The following is a description of a gene set: Human Gene Set: CHUNG_BLISTER_CYTOTOXICITY_DN species: Homo sapiens Genes down-regulated in blister cells from patients with adverse drug reactions (ADR). from publication Chung WH, Hung SI, Yang JY, Su SC, Huang SP, Wei CY, Chin SW, Chiou CC, Chu SC, Ho HC, Yang CH, Lu CF, Wu JY, Liao YD, Chen YT (PMID 19029983) Stevens-Johnson syndrome (SJS) and toxic epidermal necrolysis (TEN) are life-threatening adverse drug reactions characterized by massive epidermal necrosis, in which the specific danger signals involved remain unclear. Here we show that blister cells from skin lesions of SJS-TEN primarily consist of cytotoxic T lymphocytes (CTLs) and natural killer (NK) cells, and both blister fluids and cells were cytotoxic. Gene expression profiling identified granulysin as the most highly expressed cytotoxic molecule, confirmed by quantitative PCR and immunohistochemistry. Granulysin concentrations in the blister fluids were two to four orders of magnitude higher than perforin, granzyme B or soluble Fas ligand concentrations, and depleting granulysin reduced the cytotoxicity. Granulysin in the blister fluids was a 15-kDa secretory form, and injection of it into mouse skin resulted in features mimicking SJS-TEN. Our findings demonstrate that secretory granulysin is a key molecule responsible for the disseminated keratinocyte death in SJS-TEN and highlight a mechanism for CTL- or NK cell--mediated cytotoxicity that does not require direct cellular contact., and this is the list of marker genes: PLCG2, C12orf76, IGKC, MAX, FKBP1A, PPM1A, VCL, CFP, MTPN, MAML3, RGS18, PDLIM1, IGLC2, ITGB2-AS1, RAP1GAP2, GRB10, JPX, KIAA0513 (NCBI Gene Id 9764), SLC40A1, ADD3 (adducin 3), CSTA, HACD4, STXBP5, FOXP1, PRKCB, GAS7, GCA, KAT2B, FBXO3, NIN, RBL2, MIR223, H2BC12, PRAM1, SELL, NBEAL2, H2AC6, BIN2, IRAK3, MED13L, SNAP23, STK26, PDK3, RIPOR2 (NCBI Gene Id 9750), CDC42EP3, MNDA, P2RX1, PCMTD1, SNN, ZBTB18, FBXO38